Given this list of marker genes SPTBN1 (NCBI Gene Id 91654), SPTAN1, SPTB, SPTBN5, EPB41L2, SPTA1, SPTBN2, PRKCB, SPTBN4, here is a description of the gene set: Human Gene Set: GOCC_SPECTRIN Membrane associated dimeric protein (240 and 220 kDa) of erythrocytes. Forms a complex with ankyrin, actin and probably other components of the membrane cytoskeleton, so that there is a mesh of proteins underlying the plasma membrane, potentially restricting the lateral mobility of integral proteins. species: Homo sapiens